The following is a description of a gene set: Abnormal LDL cholesterol concentration studied in species Homo sapiens Human Gene Set: HP_ABNORMAL_LDL_CHOLESTEROL_CONCENTRATION Any deviation from the normal concentration of low-density lipoprotein cholesterol in the blood circulation., and this is the list of marker genes: APOA2, SYNE2, CEP19, TMEM43, ALG6, EMD, CELA2A, MSMO1, LCAT, LMNA, ABCG5, FHL1, LRP6, LDLRAP1, ABCG8, GHR, SMPD1 (sphingomyelin phosphodiesterase 1), FDFT1, NGLY1, CYP7A1, TTPA, SLC25A13, PCSK9, ANGPTL3, ALB, EPHX2, SLC7A7, LDLR, SAR1B, LPL, GPIHBP1, CCDC115, APOE, APOC3, B4GALT1, LIPA, SYNE1, ABCA2, TMEM199, PPP1R17, APOB, MTTP (microsomal triglyceride transfer protein), APOA5, DYRK1B